The following is a description of a gene set: species: Mus musculus Mouse Gene Set: GOBP_HEAT_ACCLIMATION Any process that increases heat tolerance of an organism in response to high temperatures., and this is the list of marker genes: Rbbp7, Hsbp1l1, Il1r1, Hsbp1, Hspa1b